Given this list of marker genes DKC1 (NCBI Gene Id 1736), COL7A1, NHP2, TERT, FERMT1, HLA-B, LAMA3, NOP10, LAMC2, DCLRE1B, TINF2, STAT3, MALT1, MYH11, IKZF1, PGM3, GRHL2, LAMB3 (laminin subunit beta 3), SAMD9, here is a description of the gene set: Esophageal stricture Human Gene Set: HP_ESOPHAGEAL_STRICTURE species: Homo sapiens A pathological narrowing of the esophagus that is caused by the development of a ring of scar tissue that constricts the esophageal lumen.